The following is a description of a gene set: Adipogenesis studied in species Homo sapiens Human Gene Set: WP_ADIPOGENESIS, and this is the list of marker genes: PPARD, CDKN1A, GADD45A, MEF2C, KLF7, LPIN1, EBF1, GATA4, NCOA1, ADIPOQ, PCK2, CNTFR, SREBF1 (NCBI Gene Id 6720), TRIB3, GADD45B, NR1H3, LPIN3, NR2F1, LEP, KLF6, SCD, TNF, E2F1 (E2F transcription factor 1), STAT2, HNF1A, WWTR1, IL6, HMGA1, LMNA, STAT1, ZMPSTE24, MBNL1, MEF2D (NCBI Gene Id 4209), FOXO1, BMP4, CTNNB1, PRLR, KLF15, PLIN2, LIPE, LPIN2, PTGIS, SMAD3, EPAS1 (endothelial PAS domain protein 1), NDN, NCOR1, CEBPD, STAT6, STAT3, DVL1, CYP26A1, CELF1 (NCBI Gene Id 10658), PNPLA3, SPOCK1, MEF2A, STAT5A, WNT5B, KLF5, FAS, BSCL2, EGR2, FOXC2, OSM, CEBPA, NCOA2, RETN, UCP1, TGFB1, CEBPB, IL6ST, CISD1, IRS4, SOCS3, CYP26B1, GDF10, GATA3, NR3C1, MEF2B, HIF1A, NAMPT, CFD, TWIST1, RXRA, RARA, ID3, PPARGC1A (NCBI Gene Id 10891), PPARG, LIFR (NCBI Gene Id 3977), SERPINE1, GH1, RBL1, AGT, BMP3, INS, BMP1, DLK1, SLC2A4, SFRP4, IRS1, FRZB (frizzled related protein), E2F4, BMP2, RORA, IRS2, GTF3A, RB1, RXRG, PPARA, PCK1, WNT1, STAT5B, AHR, NRIP1, SOCS1, LPL (lipoprotein lipase), FZD1, WNT10B, LIF, RBL2, SP1, AGPAT2, GATA2, BORCS8-MEF2B, MIF, PLIN1 (NCBI Gene Id 5346), IGF1, CREB1, ASIP, MIXL1, NCOR2, DDIT3